The following is a description of a gene set: Human Gene Set: WP_FATTY_ACID_BIOSYNTHESIS Fatty acid biosynthesis studied in species Homo sapiens, and this is the list of marker genes: ACACB, ACLY, ECH1, ACSL4, ECHS1, MECR, ACAA2, ACSS2, SCD, PC, ECHDC2, FASN, ACSL3, PECR, ECHDC1, ACSL1, DECR1, HADH, ECHDC3, ACSL5, ACSL6, ACACA